The following is a description of a gene set: Any process that modulates the frequency, rate or extent of motor neuron apoptotic process. Human Gene Set: GOBP_REGULATION_OF_MOTOR_NEURON_APOPTOTIC_PROCESS species: Homo sapiens, and this is the list of marker genes: BAX, MAP2K4, VPS54 (NCBI Gene Id 51542), CNTFR, ROCK1, RHOA, CRLF1, ZPR1, KCNB1, ERBB3, NEFL, RAPSN, MAP3K12, BCL2 (BCL2 apoptosis regulator), MAP2K7